The following is a description of a gene set: electronically inferred by orthology from the curated human pathway This event has been computationally inferred from an event that has been demonstrated in another species.<p>The inference is based on the homology mapping from PANTHER. Briefly, reactions for which all involved PhysicalEntities (in input, output and catalyst) have a mapped orthologue/paralogue (for complexes at least 75% of components must have a mapping) are inferred to the other species. part of: DDX58/IFIH1-mediated induction of interferon-alpha/beta studied in species Mus musculus Reactome Pathway: TRAF6 mediated NF-kB activation, and this is the list of marker genes: Nfkb1 (nuclear factor of kappa light polypeptide gene enhancer in B cells 1, p105), Hmgb1, Nfkbib, Rela, Nkiras1, Ager, S100b, Nfkb2, Ikbkb, Nfkbia